Given this list of marker genes EDNRB, VEGFA, BCL2, STAT1, HS3ST3B1, SMAD6, ADAMTS16, AHI1, CER1, WNT2B, CD2AP, HOXD11, KLF15, AGT, AQP1, SPRY1, WNT7B, IRX1, PECAM1, SMAD7, EYA1, RET, ADIPOQ, PAX2, FOXJ1, BMP7, MYC, MEF2C, FGFR2, SDC4, CRLF1, HNF1B, TCF21, KLHL3, NOTCH1, CITED1, PTCH1, JAG1, ROBO2, TGFB1, KIF26B, SMO, RARB, HOXB7, SOX8, WNT6, PKD2, EPHA7, SMAD5 (NCBI Gene Id 4090), CTNNBIP1, TFAP2B, NPHS1, WWTR1, LAMA5, EPHA4, FOXC2, WNT9B, NOTCH2, CD24, BASP1, FOXD1, SOX9, NOG, WNT11, BMPER, HEYL, MYO1E, SMAD3, FGF8, SHH, WNT1, CD34, CAT, CALB1, SMAD1, GDNF, GREB1L, IRX3, WT1, LIF, BMP2, EXT1, CTNNB1, HES5, WNT4 (NCBI Gene Id 54361), SLC22A6, NPNT, LGR4, HOXA11, ASXL1, SLC22A1, OSR1, AMPD2, TMEM59L, SIX2, EPCAM, POU3F3, UMOD, HS3ST3A1, KANK2, ILK, SALL1, EDNRA, IQGAP1 (NCBI Gene Id 8826), PODXL, SIX4, MAGI2, HES1, LAMB2, AQP11, PKD1, ARG2, MAGED1, EFNB2, GREM1, SIX1, GATA3, BMP4, SMAD4, SMAD2, MTSS1, AGTR2, EDN1, FGFR1, RARA, LZTS2, SIM1, FOXC1, YAP1, ACAT1, GDF11, WNK4, FGF2, GLI3, DCHS1, LHX1, DLG1, HS2ST1, GPC3, GZF1, SFRP1, PBX1, PTPRO, SLIT2, TACSTD2, PAX8, PROM1, NPHS2, IRX2, FGF1, DLL1, here is a description of the gene set: The process whose specific outcome is the progression of an epithelium in the kidney over time, from its formation to the mature structure. An epithelium is a tissue that covers the internal or external surfaces of an anatomical structure. Human Gene Set: GOBP_KIDNEY_EPITHELIUM_DEVELOPMENT studied in species Homo sapiens